The following is a description of a gene set: species: Mus musculus Mouse Gene Set: GOBP_REGULATION_OF_GROWTH_HORMONE_RECEPTOR_SIGNALING_PATHWAY Any process that modulates the rate, frequency or extent of the growth hormone receptor signaling pathway. The growth hormone receptor signaling pathway is the series of molecular signals generated as a consequence of growth hormone receptor binding to its physiological ligand., and this is the list of marker genes: Mbd5, Leprot, Leprotl1, Adrm1, Socs2, Jak2, Gdf15